The following is a description of a gene set: Bone marrow-derived macrophages were produced from mice lacking IL-10 alone (IL10-def) or mice lacking both IL-10 and the p50/p105 subunit of NF-kB (p50/IL10), and left unstimulated, stimulated with LPS (1 ng/ml) or stimulated with LPS and IL-10 (0.3 ng/ml). from publication Yang HT, Wang Y, Zhao X, Demissie E, Papoutsopoulou S, Mambole A, O'Garra A, Tomczak MF, Erdman SE, Fox JG, Ley SC, Horwitz BH (PMID 21217011) species: Homo sapiens Genes up-regulated in unstimulated IL10 knockout macrophages versus NFKB1 and IL10 knockout macrophages stimulated by LPS. Human Gene Set: GSE19941_UNSTIM_VS_LPS_STIM_IL10_KO_NFKBP50_KO_MACROPHAGE_UP, and this is the list of marker genes: ZNF606, TBL1XR1, SLC35B4, CD38, ANAPC15, RBP7 (retinol binding protein 7), PPIH, MTUS2, CA2, TDP1, INCENP, L3HYPDH, TTYH3, CENPB, EFHD2 (NCBI Gene Id 79453), MGAT5B, ARL13A, PIAS1, NCAPH, CCDC51, CDC25B, ZAN, CENPM, PIP5K1B, TICRR (NCBI Gene Id 90381), PCYT2, BUB1B, RFC1, TTL, DPYSL2 (NCBI Gene Id 1808), ZFTA, LPIN2, NEFM, FGD6, FAM110A, TFB1M, NRP1, ANKRD39, ZNHIT3, AKAP5, CD99L2, ILK, CENPN, TPGS2, HSH2D, NMT2, CMTM7, SUCO, SLC35F1, OSGEP, RAP1A, CEPT1, AKAIN1, EZH2, LRRC8C, GINS1, E2F7, SNRNP35, RIN3, MTX1, RTF1, ZXDC, CST3, BUB1, BCAS2, GPR34, SH2D3C, LRRCC1, CDCA2 (cell division cycle associated 2), PEX19, GATA3, RACGAP1, TRAPPC12, FADS1, ANP32E, TYMS, TTK, CENPJ, ITM2A, CIT, MDM1, ARHGEF16, MRNIP, ZNF362, CDK1, LRP2BP, DOK2, BEX1, GBX1, TMC4, BLM, PTPA, EVI2A, CD83, SPC24, LSP1, CSNK1D (casein kinase 1 delta), TBC1D30, EML3, COTL1, LSM2 (LSM2 homolog, U6 small nuclear RNA and mRNA degradation associated), MKRN3, CENPH, SLC4A7, ST8SIA6, APEH, CTDSP2, EHHADH (NCBI Gene Id 1962), DUSP5, KRBA1, GINS4, SLC5A3 (solute carrier family 5 member 3), DEAF1, PITPNB (phosphatidylinositol transfer protein beta), RAD54L, KIF11 (kinesin family member 11), DEPDC1B, CENPF, ZKSCAN8P1, CYC1, CLDN8, PPA2, SLF2, SKA2, RASA1, GEMIN2, SPMIP8, FOXM1, IFT80, DUSP28 (NCBI Gene Id 285193), TP53BP1, CCDC77, CDC42SE2, TMCC1, HEXIM2, PCSK1, ADAMTS6, CCR8, PPP1R7, GRK4, CELF2, PTER, PCLAF, DUSP4, LPAR3, ANKRD6, PRDM2, ABHD12, CBX5, ADCY7, URGCP (upregulator of cell proliferation), ACY3, PTCH1, CD96, APIP, SUPT16H, ZFP42, PARPBP, XDH, TOP2A, STIL, B4GALT4, C8orf33, CKAP2L, AP4M1, KYNU, APOBEC1, CCNB2, PIGR, CDKN2C, EVL, SLC25A51, ZDHHC15, SIAE, IVD, PRADC1, NRN1, PHIP, ST18, HEBP2, NOL7, USP47, CD1D, SHLD1 (shieldin complex subunit 1), TREML4, ZNF217, MAD2L1, FAM20B, ADGRE1, CDC42SE1, ASPM, BLVRA, TERF2 (NCBI Gene Id 7014), NUFIP2, DPF2, SESN1, CIB2, XRCC1, UTP11